Given this list of marker genes Sh3glb2, Lmna, Vim, Hmgb2, Mapt, Dffb, Dffa, Hmgb1, H1f3, Gas2, Gsn, Dsg1a, Stk26, Bcap31, Ptk2, Ctnnb1, Fnta, Ocln, Kpnb1, Casp3, H1f1, Casp6, Casp8, Cdh1, Casp7, Add1, H1f5, Lmnb1, Dnm1l, Dsg3, Kpna1, H1f4, here is a description of the gene set: part of: Apoptosis This event has been computationally inferred from an event that has been demonstrated in another species.<p>The inference is based on the homology mapping from PANTHER. Briefly, reactions for which all involved PhysicalEntities (in input, output and catalyst) have a mapped orthologue/paralogue (for complexes at least 75% of components must have a mapping) are inferred to the other species. electronically inferred by orthology from the curated human pathway Reactome Pathway: Apoptotic execution phase species: Mus musculus